The following is a description of a gene set: An anomaly of the complex formed by the Q, R, and S waves, which occur in rapid succession on the electrocardiogram. Abnormal QRS complex studied in species Homo sapiens Human Gene Set: HP_ABNORMAL_QRS_COMPLEX, and this is the list of marker genes: SAA1, TMEM43, SVIL, GJA5, PKP2, LAMP2, GNB2, CACNA1D, IRX5, JUP, PRKAG2